The following is a description of a gene set: species: Homo sapiens Genes up-regulated in peripheral blood monocytes (PBMC): control versus IL10. Human Gene Set: GSE43700_UNTREATED_VS_IL10_TREATED_PBMC_UP from publication Teles RM, Graeber TG, Krutzik SR, Montoya D, Schenk M, Lee DJ, Komisopoulou E, Kelly-Scumpia K, Chun R, Iyer SS, Sarno EN, Rea TH, Hewison M, Adams JS, Popper SJ, Relman DA, Stenger S, Bloom BR, Cheng G, Modlin RL (PMID 23449998) The immune mechanisms that control resistance vs. susceptibility to mycobacterial infection in humans were investigated by studying leprosy skin lesions, the site where the battle between the host and the pathogen is joined. Using an integrative genomics approach, we found an inverse correlation between of IFN-beta and IFN-gamma gene expression programs at the site of disease. The Type II IFN, IFN-gamma and its downstream vitamin D-dependent antimicrobial genes were preferentially expressed in the lesions from patients with the self-healing tuberculoid form of the disease and mediated antimicrobial activity against the pathogen, Mycobacterium leprae in vitro. In contrast, the Type I IFN, IFN-beta and its downstream genes, including IL-27 and IL-10, were induced in monocytes by M. leprae in vitro, and were preferentially expressed in the lesions of disseminated and progressive lepromatous form. The IFN-gamma induced macrophage antimicrobial response was inhibited by IFN-beta/IL-10, by a mechanism involving blocking the generation of bioactive 1,25-dihyroxy vitamin D as well as inhibiting induction of antimicrobial peptides cathelicidin and DEFB4. The ability of IFN-B to inhibit the IFN-gamma induced vitamin D pathway including antimicrobial activity was reversed by neutralization of IL-10, suggesting a possible target for therapeutic intervention. Finally, a common IFN-beta and IL-10 gene signature was identified in both the skin lesions of leprosy patients and in the peripheral blood of active tuberculosis patients. Together these data suggest that the ability of IFN-beta to downregulate protective IFN-gamma responses provides one general mechanism by which some bacterial pathogens of humans evade protective host responses and contribute to pathogenesis., and this is the list of marker genes: COA6, CXADR, APOA1, DPP6 (dipeptidyl peptidase like 6), GPN1, INSRR, EPHA2, ATF3, GTF2A1, TPK1, CLEC3B, CEP131, MYBL2, PCYOX1, KRTAP19-5, TRAK1, CCL19, ABCC8, RNF138, ATAD2B, VHL, PRKACB, ZFP36L2, PSPN, NCOA1, HP1BP3, BCL6, SPINK1, CYTIP, IPO5, SPRR2A, MERTK, CYP1A2, POLR1A, BRI3, SSR2, TUG1, MAP2K2, RMND5A, PSCA, CCNG2, ANAPC1, FPR2, NFE2L2, HMGB2, SYNRG, ZZZ3, TFDP1, PUM2, ZRSR2, APC, THY1, RBM17, ID3, RPA1, VAMP3, FMNL3, NR1I2, ECPAS, ASF1A, TECTB, LCAT, NFIA, GLRA1, GART, STYX, IL1A, VPS37B, NNAT, PMP22, DHX16, KCNJ2, ACOD1, CCRL2, NCBP2, SNCG, MOV10, TXNL4A, PDE6B, DDX27, HPS1, IFRD1, TNFAIP6, ATP9A, GPR162, DUSP1, NME6, PPFIA4, NAPB, PAFAH2, H6PD, ELF3, ENC1, DPYSL2, NR1H3, PHLDA1, FXYD1, HSD17B7, PHF12, FPR3, ALDH3A1, HCFC1, AZI2, WNT2B, SLC20A1, CD96, CRTAP, TSC1, NR2F1, IFITM10, DPYSL4, BTBD17, TENM1, DTD1, FAP, CTPS1, CMA1, EGR1, SNX9, TNFRSF1B, FJX1, TEX2, DIO1 (iodothyronine deiodinase 1), SMIM1, FOS (NCBI Gene Id 2353), PTS, DYNC1H1, PPP1R2P1, CELA2A (NCBI Gene Id 63036), LHX3, CRYGB, SPDL1, PTER, SC5D, GAPDHS, HOMER1, NGDN (neuroguidin), NMB, RPL31, HCCS, CRYGS, CBFA2T2, DUSP2, MRPL55, ALAS2, ANAPC15, ZNFX1, MELTF, CSNK2A2, PHC2, TRAPPC5, KANSL2, NR4A1, TNNI3, NOTCH2, SETDB1, MCM6, ADRB2, BCL7B, FOXD1, ZYG11B, PTPN5, DCX, FGF17, TTR, OTULINL, BTG4, CKS2, RHOB, MMP9, SEPTIN2 (NCBI Gene Id 4735), SNAPC2, ASPM, CITED2, SYNCRIP, SPINT2, SLC38A2, SMAP1, HMGA2, UBE2A, KCNJ1, CASP14, SMAD5, BCL2A1, ZNF394, MIA, VMP1, CCT2, RAX, C8orf82, CXCL3, GCGR, WDR55, HNRNPH1, BCL10, VCAN, EPB41L4A-AS1, HNRNPA1, RGS2 (NCBI Gene Id 5997), NR0B2 (NCBI Gene Id 8431)